Given this list of marker genes FKBP10, RNF168, FGB, DDHD2, RBP1, MAGT1, CLCA3P, MIER1, ABCC8, DRAM2, AGMAT, TRIP4, GPX5, DENND2C, TMEM59L, ZNF639, MED13, MYH7B, XK, C2orf72, PPFIA1, BNIP3, TADA2B, DNAJB4, CX3CL1, MRPL47, TLK1, KLF18, ADAM12, RIC1, RHOC, SUGP2, FLT1, BCAR1, WNT11, PXDN, BGN, PLA1A, EBP, WDR19, CDH5 (NCBI Gene Id 1003), C1QA, SPP2, AOPEP, ALAS2, CRX, SPATS2L, SRSF5, PTDSS2, COL11A1, AFM, C2CD2, SHOC2, SLC30A1, IGSF1, EPB42, ZSWIM7, LECT2, SLC44A1, TMEM9, RAB6A, FBN2, MAGED1, DHX57, SPTA1, HIBCH, RYK, TMEM150A, GIGYF2, TBXAS1, RBMS1, COL1A2, C1S, RNF20, IGSF3, RALGAPB, PAN3, ESAM, CPEB4, EPB41L5, MARCO, RNF157, PIR, DCN, ZNF266, TMEM132D, SLAMF1 (signaling lymphocytic activation molecule family member 1), PMM2, C2orf49, ABCC9, CELA1, CTTN, VCAM1, TSPAN7, RALBP1, CTNNAL1, MBNL1, EXOG, PTPRD, AMOTL1, TANGO2, TUFT1, ALCAM, ASCC2, SLC39A5, RHBDF1 (NCBI Gene Id 64733), COL2A1, PKDCC, EIF5A2, TREML4, CLASP2, AEBP1, C8G, HARS2, ZNF239, DNAJB2, GINS3, ASB1, ITSN1, TSPAN9, ABCC3, TNKS2, XPR1, FBXO9, ANK3, PLXNA2, TTLL5, DLK1, FABP4, CFB, PLAGL1, PIGM, DENND2B, GTF2H2, HGFAC, ALOX12, VWF, ATP5IF1, ISLR, AMOT, CWC25, AK4, ITIH3, CCDC92B (coiled-coil domain containing 92B), ITIH1, GTF2IRD2B, COP1, REC114, LUM, HSPA9, AGFG1, ZFR, TBX6, PMP22, EMSY, DMPK, SIN3A, TTR, MALAT1, RABGAP1, APOA1, NUP54, SEMA6D (NCBI Gene Id 80031), N4BP2, HBE1, C5, ETNK1, LIPG, GNL3L, NRP2, MYL9, GATA6, KNTC1, SERPINF2, TIAL1, GNG11, CRB3 (NCBI Gene Id 92359), CSNK1A1, DLL1, SLC25A4, KIF2A, FSTL1, MDM2, FZD1, BPGM, CAVIN2, TMEM30A, COL14A1 (NCBI Gene Id 7373), CTSE, SNTB1, MEG8, ASXL2, CAP2, HPN, SERPINH1, DNAJA4, CITED4, ITGA4, A2M, PRRG3, SLC39A8, GARRE1, NAP1L1, DCAF1, DUSP9, HMGCS1, ING4, CCNT1, TGFBR3, PRKAR2B, IRS2, ARIH1, RARS1, MTHFD2, DLC1, SERPINA10, APOM, SLC44A2, SV2B, ANGPTL3, PBX1, FOXO3, TBK1, PTPRF, APOA2, HS3ST3B1, IGF1R, MZT1, ARHGAP29, WDR37, SH3YL1, MYLK, TIMP3, EIF2AK1 (NCBI Gene Id 27102), STON2 (NCBI Gene Id 85439), TENT5C, NRK, ASAP1, DAAM1, FRYL, COL18A1, GCLM, IGFBP1, KIF3B, STAB2, SLC27A2, TLCD4, SNX14, LPL, FGA, FGG, OSGEPL1, FN1, PODXL, PTAR1, DEPTOR, PIGN, AHSG, SLC22A23, ALB, DAB2, CDH2, GPC3, HMG20A, NAPG, PRKAR2A, CLCN3, CA1, SMIM15, DLAT, FZD5, MIS18BP1, ZNF207, HYCC1, CFI, KIF26B, YPEL4, HSD3B1, REPS2, MESP1, OSBPL1A, RRP1B, PTGER3, EDNRB, CDSN, PON2, NDRG2, MFSD2B, NID2, ALDOC, OLA1, SERPINA6, ITIH2, CALD1, MASP1 (NCBI Gene Id 5648), PPBP, IGF2, KRT8, PICALM, IHH, C2CD3, HIPK2, HMOX1, NUDCD1, RAD18, HLA-B, PKD2, CHD8, GMPS, LOXL4, ELL2, KPNA1, PCSK7, AIRN, IGFBP7, OBSL1, UBE2O, GPC6, SUPT16H, FBXO46, CLU, ITGA2B, PER3, SLC36A2, SRXN1, AP5S1, NLK, HAUS1, TEAD1, FGFR2, CSNK1G1, NDN, LHFPL6, TRIO, FLT4, ABCA8, VTN, COL5A2, CD59, DCBLD2, EPS15, SEMA4G, C1GALT1, COL1A1, KMT5B, FERMT2 (FERM domain containing kindlin 2), PTPRB, EXD1, RESF1, ABCG2, HECTD1, ABCA1, OGA, FTSJ1, BMP2K, CIAPIN1, PEG3, KNG1, SREK1IP1, SEPTIN2, OGFRL1, CGN, DNM1L, HPX, MIB1, MBOAT2, XPO4, ENOX2, SLC38A4, APOH, WDR43 (NCBI Gene Id 23160), RAB36, CYP2C8, BFAR (bifunctional apoptosis regulator), MAGEL2, PLS1, HARS1, PPP6R3, PRSS53, LARP4B, CYLD, AADAC, ANKRD39, CCNC, LOXL2, USP8, MSR1, ASPH, MEG3, MLLT3, SETDB1, ACTB, COL6A2, FOXP2, NT5C3A, PITRM1, GYPA (glycophorin A (MNS blood group)), MLXIPL, PLEK2, ANKH, MPZL2, TCEAL9, DNAJC22, LGR6, ACOX2, TENT2, NTMT1, KMT2A (lysine methyltransferase 2A), LUC7L2, ITM2A, SEMA5B, TMEM158, ME1, IL1B, AFTPH, UGT2B4, COL3A1, RBP4, IRGM, SPARC, F2, HNF4A, HERC4, SBNO1, VOPP1, HBG1, RNF128, ARMC1, ACSL4, TRIM10, SLBP, NSFL1C, GHR, KLHL20 (kelch like family member 20), SNCA (synuclein alpha), AFP, LPP, CXADR, DUSP8, NR1H3, AKR1B10, MKRN1, SLC23A2, APOB, ZBTB45, GUCY1A1, TMC7, ARFGAP2, TRMT10A (NCBI Gene Id 93587), ATP1B2, CLK2, GAS2L1, TOP2A, SERPINC1, SLC30A10, CPSF2, ELOC, COL4A1, CRP, CHAC2, PUM2, CYP2D6, MT1F (metallothionein 1F), ZFAND5, SCAI, LPIN2, IRAG1, MIOS, IGFBP2, INSR, RPS6KA3, SGMS1, SLC6A8, MLPH, BOLA2, PPOX, SEPTIN4, SERPING1, HUWE1, GC, AGRN, SDC2, KEL, BTN1A1 (NCBI Gene Id 696), PLG, CAMK2N1, PRSS40A, FECH, EXOC6, RBM5, H1-4, TTC39A, FOXH1 (NCBI Gene Id 8928), FAM114A1, CEP76, WWC1, GRB10, AMBP, TF, here is a description of the gene set: Human Gene Set: PILON_KLF1_TARGETS_UP species: Mus musculus Genes up-regulated in erythroid progenitor cells from fetal livers of E13.5 embryos with KLF1 knockout compared to those from the wild type embryos. Erythroid Krüppel-like factor (EKLF) is a Krüppel-like transcription factor identified as a transcriptional activator and chromatin modifier in erythroid cells. EKLF-deficient (Eklf(-/-)) mice die at day 14.5 of gestation from severe anemia. In this study, we demonstrate that early progenitor cells fail to undergo terminal erythroid differentiation in Eklf(-/-) embryos. To discover potential EKLF target genes responsible for the failure of erythropoiesis, transcriptional profiling was performed with RNA from wild-type and Eklf(-/-) early erythroid progenitor cells. These analyses identified significant perturbation of a network of genes involved in cell cycle regulation, with the critical regulator of the cell cycle, E2f2, at a hub. E2f2 mRNA and protein levels were markedly decreased in Eklf(-/-) early erythroid progenitor cells, which showed a delay in the G(1)-to-S-phase transition. Chromatin immunoprecipitation analysis demonstrated EKLF occupancy at the proximal E2f2 promoter in vivo. Consistent with the role of EKLF as a chromatin modifier, EKLF binding sites in the E2f2 promoter were located in a region of EKLF-dependent DNase I sensitivity in early erythroid progenitor cells. We propose a model in which EKLF-dependent activation and modification of the E2f2 locus is required for cell cycle progression preceding terminal erythroid differentiation. from publication Pilon AM, Arcasoy MO, Dressman HK, Vayda SE, Maksimova YD, Sangerman JI, Gallagher PG, Bodine DM (PMID 18852285)